The following is a description of a gene set: Any process that activates or increases the frequency, rate or extent of long-term synaptic potentiation. Mouse Gene Set: GOBP_POSITIVE_REGULATION_OF_LONG_TERM_SYNAPTIC_POTENTIATION species: Mus musculus, and this is the list of marker genes: Fmr1, Ptpn5, Adrb1, Cpeb3, Akap5, Sqstm1, Drd2, App, Crtc1, Adcy1, Shisa7, Mme, Reln, Stau1, Slc18a3, Lgmn, Adora2a, Nrgn, Creb1, Nos1, Zdhhc2, Eif2ak4, Nptn, Igsf11, Prkar1b, Pde9a, Chrna7 (NCBI Gene Id 11441), Shank3, Drd1, Ephb2, Hnrnpk, Adcy8